The following is a description of a gene set: studied in species Homo sapiens Human Gene Set: GOBP_REGULATION_OF_G_PROTEIN_COUPLED_RECEPTOR_INTERNALIZATION Any process that modulates the frequency, rate or extent of G protein-coupled receptor internalization., and this is the list of marker genes: APLN, APP, NECAB2, APELA, UBQLN2, APLNR